Given this list of marker genes Ret, Nog, Agtr2, Ppp3ca, Pax2, here is a description of the gene set: studied in species Mus musculus Mouse Gene Set: GOBP_POSITIVE_REGULATION_OF_GLOMERULUS_DEVELOPMENT Any process that increases the rate, frequency or extent of glomerulus development, the progression of the glomerulus over time from its initial formation until its mature state. The glomerulus is a capillary tuft surrounded by Bowman's capsule in nephrons of the vertebrate kidney.